The following is a description of a gene set: from publication Gao S, Yan L, Wang R, Li J, Yong J, Zhou X, Wei Y, Wu X, Wang X, Fan X, Yan J, Zhi X, Gao Y, Guo H, Jin X, Wang W, Mao Y, Wang F, Wen L, Fu W, Ge H, Qiao J, Tang F (PMID 29802404) Human Gene Set: GAO_LARGE_INTESTINE_ADULT_CH_MKI67HIGH_CELLS studied in species Homo sapiens, and this is the list of marker genes: NDC80, PARPBP, CDC45, TPX2, NEURL3, ARHGAP11B, RDM1, FANCD2, GJB7, FEN1, LINC00628, STAG3, GTSE1, ERCC6L, KIF11, KIF20A, TROAP, KIF23, CENPA, LYPD5, TDRKH, OIP5, POC1A, FAM111B, CDCA5, TEDC2, RAD54L, ELAVL2, FANCB, DIAPH3, AURKB, TMEM237, NCAPH, PLK4, CENPF, CDCA2, NUF2, DDIAS, TACC3, MNS1, DDX11-AS1, RGP1, IQGAP3 (IQ motif containing GTPase activating protein 3), CHAF1B, RAD51AP1, CIP2A, ESCO2, KIF2C, RAD51, HJURP, ANLN, TOP2A, BUB1B, PBK, CCNA2, CKAP2L, MYO3A, ESPL1, E2F8, PDIA2, CDC25C, DTL, EXO1, H1-5, CIT, SKA3, CDCA3, DNA2, KIFC1 (NCBI Gene Id 95229), BIRC5, BUB1, TMPO-AS1, REXO5, KIF4A, CENPH, CCDC74A, ZNF599, THAP10, DSCC1, KIF15, NEIL3, SERPINA6, ARHGAP11A, CEP55, FCAMR, MYBL2, APOBEC3B, DEPDC1B, PKMYT1, UBL7-DT, NRM, CDCA8, FAM201A, CDH16, HROB, HMMR, PIF1, PIMREG, MCM10, RAD54B, MKI67, DEPDC1, FOXM1, MAILR, EME1, NCAPG, TRIP13